Given this list of marker genes Pten, Fam107a (family with sequence similarity 107, member A), Jag1, Cask, Clasp2, Nf1, Acer2, Lrp1, Serpine1 (serine (or cysteine) peptidase inhibitor, clade E, member 1), Rcc2, Itgb1bp1, Myoc, Rasa1, Cdkn2a, Acvrl1, Apod, Ajap1, Coro1c, Adam15, Pik3r1, Sema3e, Dmtn, Nexmif, Mmp12, Mmp14, Src, Hoxa7, Arhgap6, Phldb2, Thbs1, Bcl6, Enpp2, Dlc1, Muc4, Dusp22, Plet1, Postn, here is a description of the gene set: studied in species Mus musculus Mouse Gene Set: GOBP_NEGATIVE_REGULATION_OF_CELL_MATRIX_ADHESION Any process that stops, prevents, or reduces the rate or extent of cell adhesion to the extracellular matrix.